The following is a description of a gene set: Comprehensive identification of all functional elements encoded in the human genome is a fundamental need in biomedical research. Here, we present a comparative analysis of the human, mouse, rat and dog genomes to create a systematic catalogue of common regulatory motifs in promoters and 3' untranslated regions (3' UTRs). The promoter analysis yields 174 candidate motifs, including most previously known transcription-factor binding sites and 105 new motifs. The 3'-UTR analysis yields 106 motifs likely to be involved in post-transcriptional regulation. Nearly one-half are associated with microRNAs (miRNAs), leading to the discovery of many new miRNA genes and their likely target genes. Our results suggest that previous estimates of the number of human miRNA genes were low, and that miRNAs regulate at least 20% of human genes. The overall results provide a systematic view of gene regulation in the human, which will be refined as additional mammalian genomes become available. studied in species Homo sapiens Genes having at least one occurrence of the highly conserved motif M140 RNGTGGGC in the regions spanning 4 kb centered on their transcription starting sites. The motif does not match any known transcription factor binding site. from publication Xie X, Lu J, Kulbokas EJ, Golub TR, Mootha V, Lindblad-Toh K, Lander ES, Kellis M (PMID 15735639) Human Gene Set: RNGTGGGC_UNKNOWN, and this is the list of marker genes: PAFAH1B3, SLC39A3, RAMP2, DALRD3, FBXO36, MRGPRF, EPAS1, GSE1, TLK2, DYNC1I1, RPA3, E2F4, BPIFA3, LCK, LAD1, CABP2, TMCC1, AGL, TMEM60, HLX, GGA1, NEUROG1, FLRT3, XPO7, SRSF5, CARF, ARMCX2, BEST1, IRX5, AHNAK, UCHL3, CADM2, CELSR2, SUN2, DLG2, NXPH3, TMEM256, SLC6A13, NDUFAF3, HRK, ALDOA, KIF2C, MXI1, NRF1, CLDN14, PTTG2, PDIA3, COL9A3, MOSPD3, DRD1, SRF, EPHB3, RAB11FIP5, SERPINB3, CDH5, ATP5MC3, CKM, SLC24A1, DBP, RORA, EFNA5, TPBG, TRERF1, CHRM4, KDELR1, ERGIC3, ENTHD1, DMBT1, LSR, ZCWPW1, BTG1, ADK (adenosine kinase), MORC3, MAP1A, H4C8, HERC4, RAPGEF3, TAFA1, RABL6, RNF43, HOXC10, KCNV1, SORL1, PDGFB, CREBRF, SCGB3A1, HOXA11, OVOL1, CERT1, CACNB3, WWP2, NRAS, USP4, FAM13B, WNT6, ADAMTS15, CERS5, CCDC148, ANKHD1, MEIS2, MGP, QRICH1, NHS, TEPSIN, POLR2A, OVOL2, NRGN, POLK, CYP11A1, NHSL2, ADD3, ZEB2, SYNJ1, MYO1H, LRRN2, ANGPTL1, IRS4, FKBP5 (NCBI Gene Id 2289), IPO13, ACY1, CSRNP3, NPM1, SYNCRIP, CORO6, ATG2B, PPP2R2B, GLB1L, PKP4, LONRF3, FSBP, BDNF, ARL4A, LNPK, ADAMTS14, LRRC74A, COBL, ADGRG1, MICAL2, GPC3 (NCBI Gene Id 6394), RARA, NKX2-2, FMNL2, SEMA3B, NPR3, KCNJ14, NPSR1, ELAVL4, RTBDN, KLK13, USH1G, TNFSF12, TET2, LRRC8A, NR4A1 (nuclear receptor subfamily 4 group A member 1), SYT7, CMTR2, RAB11A (NCBI Gene Id 8766), MIDEAS, CAPN6, SPEM1, DLK2, RIMS4, SENP6, CCND1, PLD5, SMOC1, SH3GL3, USP49, SEZ6, RALGPS2, KIF16B, KLF12 (KLF transcription factor 12), NCOA5, HCRTR1, SLC26A7, MKNK2, NT5DC2, DIP2B, SPTAN1, GJB1, SYNGR3, CORO1C, C19orf73, SLC8A3, EVX1, HDDC3, WFIKKN2, AP3M1, WDR44, APBA1, C6orf62, MCUR1, ANKRD17, HHATL, HS3ST3A1, RNF5, RAB22A, VEGFA, MBD6, HNRNPL, RUNDC3B, DUSP22, GPR61, HMGN2, KIF3C, CD53, C9orf72, MARCHF8, SAP130, SFTPC (NCBI Gene Id 6440), CYB5D1, POLR1G, LRP2, NEUROD6 (NCBI Gene Id 63974), B4GALT2, UBXN10, FRY, KCNIP3, PRPF6, CPA4, DCAF1, B3GALT2, NUDT8, MTAP, TLE4, TNPO2, SPIB, COL8A1, BTBD3, GFI1, KRT8P41, SLC24A3, HOXA10, PTPRE, VTN, SMYD5, HAPSTR1 (HUWE1 associated protein modifying stress responses), RPL22, GABBR1 (gamma-aminobutyric acid type B receptor subunit 1), RGS14, ZMYM5, PGF, KLK6 (kallikrein related peptidase 6), FGF12, CSDE1, EPHB1, FABP3, EMX2, CBLB, XPNPEP3, PPL, UBE2Z, TFEB, PGRMC2, KCNH2, CITED2, ATOH7, SEMA4A, ODF2, ITPKB, IDH1, COPZ2, MNT, MTNAP1, KAT7, PAK3, ZMYM3, GYPC, NCDN, STAT6, SLCO3A1 (solute carrier organic anion transporter family member 3A1), DENND2B, CGGBP1, TAFA4, ADISSP, PPFIA3 (NCBI Gene Id 8541), VCF1, PCSK2, LRRFIP1, GRIN2A, ATOSB, TFAP2B, PTMA, CCDC69, MUC1, DNMT3A, SALL1, CATSPER2, VWCE, MACROH2A2, SDF2, TRIM29 (NCBI Gene Id 23650), CPNE4, TRAF4, MRPS18B, SHANK1, PRM2, NOL4L, CKAP4, E2F3, REPIN1, APP (amyloid beta precursor protein), HMGN3, ANKHD1-EIF4EBP3, E2F1, TUSC3, FBXO28, CEBPB, HEXIM2, SMG5, RHBDD3 (rhomboid domain containing 3), PRRC1, SOX4, PUS10, ANKRD39, NRDC, PSME3IP1 (NCBI Gene Id 80011), TMEM151A, PRKCB, FST, ATG12, RPS6KA3, HOXD10, PKD1, ADAMTS2, EGFL6, MPP2, VPS29, PCBP4, LAT, HIP1R, TMEM88, ASPHD1, SUPT16H, C9orf85, RBBP6, GPR162, GPC4, RERE, DNAJB5, PHOX2B, ROS1, NEURL1, RELL2, MAN2A2, DCTN3, BEST2, STX4, RASSF7, FAM78A, PLCD3, CD86, ADAMTS9, GPRIN3, SPEG, LTBP3 (latent transforming growth factor beta binding protein 3), KDM3B, SYT8, LCNL1, RCOR2, AMPD2, DYNLL1, WNT5A, DMTF1, INO80, TTBK2, OR3A2, ALKBH6, GRB14, EYA3, INCA1, ST13, TAOK2, PRRX1, KRT17, SELENOI, ATXN7L2, CCDC106, OTOF, PBX1, PCED1A, THOC6, ELOVL5 (NCBI Gene Id 60481), MSL2, CLUH, PDLIM2, STK16, CCND2, RAB5C, RPL36AL, S1PR1, RALY, PPP1R16B, CCKAR, NUFIP2, SOBP, LMTK2, EPB41L3, TP53BP1, VLDLR, APLNR, KCNN3, PROM2, TULP2, VPS16, BEGAIN, PCIF1, KANSL3, RSPRY1, ZNF777, GIT1, LRRC3B, TRIB1, RTL9, KLF7 (KLF transcription factor 7), PPM1E, DUSP11, TMEM184A, EGFLAM, RHBDL3, TMEM74, ELK1, RSF1, BAHD1, SRRM4, RANBP1, NAB2, MAML3, ANKRD13D, KCNB1, CYB561D1, MEGF8, PTCH1, NR6A1, PSMB3, AMDHD2, ACVR2A, PPP1R10, LARP4, PANK3, SP4, MYNN (myoneurin), CHRM1, BMP6, PTPN6 (NCBI Gene Id 5777), EGR3, DIAPH1, KCNH4, ATXN7L1, NOP53, NRG2, ZMYM2, FOXP1, STRIP1, LTBP2, CNOT9, ZBTB4, GAPDH (NCBI Gene Id 2597), ABHD17B, SIN3A, KLF6, CNIH2, MEPCE, LSMEM2, YWHAG, HDAC3, CADM3 (cell adhesion molecule 3), PACSIN1, RRM1 (NCBI Gene Id 6240), RTKN, FGFRL1, SLC4A10, OSTC, RAD9B, ATF6B, BCOR, NR2E1, LIME1, CALD1, NACC1, AGAP1 (ArfGAP with GTPase domain, ankyrin repeat and PH domain 1), DLC1, RNF145, FADS3, NMU, CBFA2T3, CREB3L2, BMI1, EFNB1, H3-3B (NCBI Gene Id 3021), ATP6V1B1, PPM1D, MPZ, DLG3, HOXC11, LRRN1, DMPK, UPRT, P2RX6, PRELID1, NRK, CFAP65, PTGR3, AANAT, TKFC, FBXL2, DOC2B, SNORC, CALM3 (NCBI Gene Id 808), CCDC102A, JADE1, SLC50A1, FGF10, VAT1, BCL7C, S100A3, KLF5, HOMEZ, ZNF575, RAB24, UNC80, NFIB, L1CAM, CEP41, SPRY4, MACROD1, SOX14, PEX13, PRX, SHH, MRPL40, TLL1, AQP2, DIO3, SLC4A1, PACS1, CHRNB2, PICALM, SFXN2, CSMD3, ACSL4, CASKIN2, COL26A1, SLIT3, SHISA6, PANK1, MYRF, FZD5, ATP2B4, ATP8B2, XPNPEP1, SLC25A1, HOXC5, DAB1, LRP1, RRBP1, TMEM117, CELF4, PRMT3, CPNE8, AP1S1, CKB (creatine kinase B), IDH2, MAMSTR, AIFM3, IPO7, IL2RA, CCDC88A (coiled-coil domain containing 88A), AP3B2, VAMP5, PHF12, SSB, PCOLCE, RTN4R, SIX4, TNFSF12-TNFSF13, COLQ, ARL3, ITGB8, AKAP10, STARD4, SIK3, NEDD9, NCAM1, SERTAD1, NRCAM, SH3RF1, EIF3J, DPYSL2, TSC22D1, PPP2R2C, RSPO2, GJB4, AK3, PIP4K2B, LRATD1, EXOC6, NECTIN1, HIRA (NCBI Gene Id 7290), WDR81, KLHL4, FGF11, PIM2, ERF, EFNB3, SSTR1, FOXJ3, RARG, CDKL5, PRPS2, ASIC2, CCDC71L, PLA2G3, TRPC4, GLI1, HSP90AB1, EPHB6, SMARCA5, PPP3CB, FOXD3, TLCD4, EXT1, CHST6, C1orf21, INSRR, TLX3 (NCBI Gene Id 30012), KCNB2, STIP1 (NCBI Gene Id 10963), ARPC5L, BCL9, PRR15, TRMT2A, DVL2, SLC4A2, DHX35, PTK2B, NR1D1, HOXA7, G6PC3, EMX1, PDGFRB, TCEAL3, CD74, EFEMP2, OTUD5, SLC39A5, BMP3, CHL1, CD79B, PAX9, SLC1A1, SARM1, SLC25A39, OBSCN, TGIF2, FPGS, OGG1, B4GALT1, CALU, RGS17, PDP2 (pyruvate dehydrogenase phosphatase catalytic subunit 2), TGFB1I1, FOXA1, SEPTIN4, C2orf42, TMSB10, CCKBR, LDLRAD3, TGM3 (transglutaminase 3), HIF1A, PNLDC1, EP300, TBCC, KRT14, AKAP12, SUPT6H, FBXW7, HOXB7, NPHP4, SYNRG, UTP18, PLP2, HEPACAM, RCC2, XK, LMNTD2, PITX2, PFKFB3, USP37, HNRNPDL, SPATA2L, FYN, CIPC, SIT1, NR4A3, STMN2, SH3KBP1, UCKL1, GNA13, PSMC6, ZNF408 (NCBI Gene Id 79797, zinc finger protein 408), TSR1, OR2L13 (NCBI Gene Id 284521), ARHGAP1, DCTN1, NONO, VAMP3, SNX25, FBXL18, ARIH1, TMEM95, FMR1, KIF1C, PTBP2, DMD, ADAMTS13, BMPR2, NOL6, IGF2BP1, CRHR1, MAGI1, RBM26, HCFC1R1, GPRC5C (G protein-coupled receptor class C group 5 member C), KCTD15, AAMDC, LRRC8D, ARHGEF17, FABP6, SAFB (NCBI Gene Id 6294), CCDC120, ATL1, RRM2B, JADE3, TNS2, ADAMTS3, FOXG1, APLN (apelin), CA14, KLF10, CAMK2A, BMP4, FLT1, MORC1, PARD6A (par-6 family cell polarity regulator alpha), TBX5, CAMKK1, OLIG1, PDLIM4, AK2, IL2, KCND3, KCND1, NUCB1 (nucleobindin 1), NR3C1, ST8SIA2, RRAS, CSTF3, NAA38, MTTP, GNAS, NLK, RBMS3 (NCBI Gene Id 27303), CACNA1A (calcium voltage-gated channel subunit alpha1 A), RAB2A, EWSR1, MIR22HG, GIGYF2, SERPINB4 (NCBI Gene Id 6318), SOCS5, SATB2, MGAT2, TMEM79, NRG1, R3HDM1, B3GNT7, PDE10A, SH3GLB2, RPS19, SAMD10, SLC12A5, AP3S1, FGF23